The following is a description of a gene set: Cell types are named using anatomical and functional mnemonics prefixed by 'm' or'h' to indicate mouse and human respectively: OMTN, oculomotor and trochlear nucleus; Sert, serotonergic; NbM, medial neuroblast; NbDA, neuroblast dopaminergic; DA0-2, dopaminergic neurons; RN, red nucleus; Gaba1-2, GABAergic neurons; mNbL1-2, lateral neuroblasts; NbML1-5, mediolateral neuroblasts; NProg, neuronal progenitor; Prog, progenitor medial floorplate (FPM), lateral floorplate (FPL), midline (M), basal plate (BP); Rgl1-3, radial glia-like cells; Mgl, microglia; Endo, endothelial cells; Peric, pericytes; Epend, ependymal; OPC, oligodendrocyte precursor cells. Human Gene Set: MANNO_MIDBRAIN_NEUROTYPES_HGABA species: Homo sapiens from publication La Manno G, Gyllborg D, Codeluppi S, Nishimura K, Salto C, Zeisel A, Borm LE, Stott SRW, Toledo EM, Villaescusa JC, Lönnerberg P, Ryge J, Barker RA, Arenas E, Linnarsson S (PMID 27716510), and this is the list of marker genes: BRSK2, BOD1L1, PILRB, MICU3, MAPRE3, PPFIA4, PEX1, POU2F1, BACH2, SSH2, DUSP26, MVB12B, GOLGA8J, LRRC49, PRSS12, AFF3, TMEM255A, RUFY3, SLC24A3, ENSG00000255240, FNBP1L, LRRC2 (leucine rich repeat containing 2), DNM3, FAM81A (NCBI Gene Id 145773), GABRB2, TAFA5, CDRT4, CATSPERG, PCDH9, CSGALNACT1, SGMS1-AS1, SYNPR, STMN2, PPP3CB, PCDH11X, AMER3, SMPD3 (sphingomyelin phosphodiesterase 3), F11R, MARCHF1, NPFF, SOCS7, FAM217B, SNAP91, FRY, CALB2, NRP2, SV2B, BCL11A, STK32B, RFX7, CMIP, EPB41L1, NT5DC3, CDON (cell adhesion associated, oncogene regulated), RUNX1T1, SLC17A6, DACT1, SMIM17, VAV2, C11orf87, MAST4, MEGF6, PLCXD3, CCDC88A, SLC6A1, DIP2B, MAP6, PCLO, DND1, TBC1D3, CLVS2, LRRC3B, AKAP9, WASF1, TSPAN7, HBG2, PXK, GNAL, VSTM2A, AKR1C2, SNTG1, ZNF793, KRT14, AGTPBP1, SORBS1, GABRB3 (NCBI Gene Id 2562), LSAMP, LBH, SHROOM2, PIK3CD, CHST11, FAR2P2, GDPD1 (glycerophosphodiester phosphodiesterase domain containing 1), NCAM1, THSD7A, ACSL6, IRF2BPL, FMNL2, TAFA2, NCR3LG1, RB1CC1, MAGI3 (NCBI Gene Id 57725), KCNQ1OT1, BRWD1, IRX3, GABRG2, CNR1, HPCAL4, RNF146, PIANP, LAMC2, CRIM1, OTP, ZNRF1, LRRC7, TMEFF2, TULP4, CD2, FAT2 (FAT atypical cadherin 2), GNAO1, CACNA1A, CSNK1G2, BZW2, PRRT4, KCNC1, MSR1, MIR3945HG, RAB3B, NDST3, ARL8A, DLG2, ATP1B1, DCX, SEMA6D, NNAT, CGN, CREG2, UNC13A, TMEM74B, NRXN3, CPNE5 (NCBI Gene Id 8901), CADM1, KCNC2, LHFPL3, CACNB3, ST8SIA3, KIAA1549, CCDC112, HOOK1, UBXN2B, FBLL1, MTUS2, AKR1C1, CACNG2, KCNA3 (potassium voltage-gated channel subfamily A member 3), GPRIN3, VSNL1, GNG2, LYSMD2, NBEA, TRIM67, CDH22, SV2C, SNX1, SEMA3A, GRM4, RIMS1, COL6A6, GABPB1-AS1, FAM219A, IKZF4, SMARCC2, EEA1, TMEM163, MED13L (mediator complex subunit 13L), SLC25A22, SDC3, ADARB2, EID2B, ADAP1, ROBO1, FRMD5, FRMD4B, SPATA13, ADAMTS3, HIVEP3, C2CD6, PRLR, MTSS1, DIRAS2, LRP12, PDE1B, PRRT2, SYTL2 (synaptotagmin like 2), RASAL2, PLEKHA1, ANKRD36, CELF6, VPS53, SLC5A3, KCNIP4-IT1, DNER, PCDH17, TRHDE, BLCAP, SYCP2L, CACNA1C, SAMD11, MCF2L, TTC9, CDKL2, ERC2, ENTREP2, CYRIA, CDH13 (NCBI Gene Id 1012), ZC3H8, TNK2, PGM2L1, IKZF3, CHN2, ARFGEF3 (NCBI Gene Id 57221), STOX2, GLRA2 (NCBI Gene Id 2742), SCN2A, LMOD3, CCDC17, UGCG, KBTBD11, MTURN, CSMD3, NTNG1 (NCBI Gene Id 22854), ATP2B2, NECTIN1, MAB21L1, RAI1, PLXNA3, MAP1B, RAB11FIP4, PLXNC1, PRICKLE2, SRGAP1, SMURF1, CD24, GAD2, ADCY1, CYLD, BRD1, SYN3, PLPPR1, SHTN1, LPAR2, RASGEF1B, FHOD3 (formin homology 2 domain containing 3), RASA4, PDZRN4, EBF2, ELAVL4, LRP1B, GRIK2, PACS1, NALCN, THRA, DOK6, EFHC2, AHNAK2, PDIK1L, SARDH, RIMS3, GRIA1, PDZD7, MSANTD3-TMEFF1, KCNN3, DBET, CSRNP3, CACNA1I, IRX2, NPNT, TCEAL5, SEC31B, AHDC1, NEGR1, UBE2Z, SYNJ1, NSG2, MAP2K3, PTPRO, ST8SIA2, MFSD6, CNOT6L, CHST1, PRKAA2, LIN54, TMEM178B, SLITRK4, DOK4, CELF1, PPARGC1A, FNDC5, SRSF12, RALGDS, RBMS3, ATCAY, TANC2, N4BP2, RETREG2, MGAT5, PKIA, DPF1, MAP3K2 (mitogen-activated protein kinase kinase kinase 2), SLC6A15, FNDC9, STRIP1, SIK3, ARHGAP23, BCL2L15, PCDH19, CELSR3, CASKIN1, GOLGA7B, SPINT2, POU3F2, HYDIN, AMER2 (APC membrane recruitment protein 2), GDAP1, SERPINI1, PRNP, PREPL, MUC2, BLID, WNK3, PIAS2, FUT9, SUGP2, OSBPL6, PPP2R3A, MAPK8IP2, ASIC2, KIFAP3, LGR5, FBXO48, COL8A1, RAPGEF5, SLC25A12, DYRK2, TSIX, ZNF318, LHFPL4, GRIA4, CHIC1, TRIM9, KLC1, RTN4, SP4, NAPB, BDP1 (B double prime 1, subunit of RNA polymerase III transcription initiation factor IIIB), PIEZO2, ATP8A1, SSPOP, CSAD, PDZD4, TTC3, CHRNA4, MAPRE2, HS6ST2, RCOR2, PNCK, ASNS, CACNB4, CNTN5, PCDH8, PDE4DIP, LONRF2, CDK5R1, HBE1, JAG2, GFRA1, LARP1B (La ribonucleoprotein 1B), CYTH1, MBLAC2, SNORD116-29, CHD3, SPOCK2, FAXC, ZNF385D, RBM33 (RNA binding motif protein 33), AKAP6, ACSL4, OPRM1, GPRASP1 (G protein-coupled receptor associated sorting protein 1), SLC7A14, TAOK3, PRDM2, NAP1L2, OGDHL, POU2F2, SHOX2, DCLK3, LRRC4B, RGS6, TARBP1, NOVA1, PRAMEF1, SRGAP3, LPCAT4, CALN1, TCERG1, MICAL3, ABCC5, PWAR1, AP3B2, SPOCK1, RNF157, PRKAB2, EPHB1, CEMIP, KCNIP4, GPR26, SGK2, LINGO1, SEMA3C, TNKS, FAM184A, TTN, SLC9A6 (NCBI Gene Id 53362), DOK3, KIF21B, UBQLN2, BEND4, NOL4L, GPR176, RAB3A, TAC1, DOCK3, FKBP15, FAM114A2, RIMS2, TERF2IP, MYO5A, GPC2, MTUS1, B3GALT2, RBFOX3, RYR2, MYT1L, SPOCK3, ANO8, SLC16A9, DPYSL3, RBM26, ACVR2A, ADGRD1, CHGA, NXPH2, PSD2, ENOX1 (ecto-NOX disulfide-thiol exchanger 1), ABR, GOLGA3, PAK3, GALNT15, SLC32A1, BIVM-ERCC5, DOP1B, TENM1, VASH2, BDNF, SLITRK5, ATL1, CLCN4, NFASC, MAGI2, CXCL5, RUNDC3B, RUSC2, MCF2, ZMYND8, REV3L, PPP2R2B, KCNK2, EHD4, ENSG00000254951, ESRRG, B4GALNT4, GATA3 (GATA binding protein 3), GABRG1, RNF112, ZNF697, FAM43B, CELF4, TMEM121B (transmembrane protein 121B), BSN, MIR124-2HG, DPP6, SVOP, GAD1, MEG3, NALF1, GABRA1, OTUD4, ARL4C, TNRC6A, SST, IDS, KIF13A, SCN3A, SAMD8 (sterile alpha motif domain containing 8), SIX3, SHISAL1 (NCBI Gene Id 85352), CCDC186, CEP85L, NLGN4X, ARID4A, GRIA2, SULT4A1, RAP1GAP2, NEDD4L, NPTXR, ANK3, CRMP1, ZNF28, CACNA1G, XKR6, UBN2, PLXNA4, ELAVL2, NLGN1, CREBRF, ENC1, TES, DOCK4, NETO1, LONRF1, SH3KBP1, NDRG4, SECISBP2L, RAPH1, TNRC6C, PCDHB4, TSPYL4, GNAZ, OPTN, CBX4, MDGA2, VAV3, DHX33, CPEB4, GRK3, SCIN, SLC6A17, SSTR2, DAAM1, APBA1, CELF2, EPHA3, TCEAL2, CCDC184, ARHGAP35, AP1S2, SH3PXD2A, NRXN1, TBC1D2B, GRM5, ARMH4, PDE4C, DNAJC12, ZMAT1, MYO7A, CCDC141, RABGAP1L, NAP1L3, AUTS2 (activator of transcription and developmental regulator AUTS2), NELL1, ARHGAP24, MACO1, EN2, C17orf67, ZFHX2, ABCA3, ADAMTSL4-AS1, ZFHX3 (NCBI Gene Id 463), SAMD5, NREP, NAP1L5, SYT13, ZBTB43, HNF1B (NCBI Gene Id 6928), OLFM1, GPD1L, TTC9B, SPEG, CEP126, NINL, SOX11, ZCCHC12, STEAP2 (NCBI Gene Id 50630), RUNDC3A, INSYN2A (inhibitory synaptic factor 2A), CAMSAP2, ARPP21, ACVR1B, PTPN5, DSCAML1, CHN1, TVP23C, AP1S3, SRRM3, SLC4A8, SORCS3, RICTOR, LPIN1, EFNA5, SLC4A3, KSR2, PNMA8B, SYT4, MYT1, GRID2, SCD5, STMN4, CSMD2, JPH1, RGS7BP, HYCC2, CASK, TAL1, ICA1L, RGS17, PCP4, NRXN2, DLG3, SRCIN1, KLF7, YWHAG, DNAJB14, UCHL1, TMEM185B, KIF3A, INPP4A, NPAS3, LGI2, KLHL14, NGEF, ATRX, PCOLCE2, GRIN3A, ZBTB38, CA1 (carbonic anhydrase 1), KDM2B, NMNAT2, APBA2, CDC42EP3, ZNF462, MPP3, SCN9A, ATP9A, SRRM4, PDE7A, CADM3, TMEM132B, KIF21A, RETREG1, TMEM151A, SH3BP5, PLCB4, GPM6A, DNM1, IGSF3, CITED2, DMTN, SCN8A, BIVM, PCDHA7, UBE2QL1 (NCBI Gene Id 134111), TMEM35A, RIMBP2, TCERG1L (transcription elongation regulator 1 like), DACT3, CPEB2, XPR1, MTMR6, ARK2C, SPAST, C3orf62 (chromosome 3 open reading frame 62), ZYG11B, SLITRK1, NKAIN2, HCFC2, ARFGEF1, TBC1D9, PPP2R2C, FAM117B, SSBP3, KHDRBS3, LSM11, PNMA2, DNAJC6, PPARGC1B, PNOC, SV2A, SHANK3, VGF, DGKE, NCS1, PTPRK, KIF1A, CNTN4, SBF2, CNTN1, PLXNA1 (NCBI Gene Id 84202), DICER1, MAP3K9, SEZ6L2, CBLN4, STXBP1, FGF14, MIA3, ZNF471, HERC1, PAK5, TPD52L1, RALGPS1, ARHGEF12, GAP43, CSMD1, PRKAR2B, NALF1-IT1, ANK1, B3GAT1, GPR155, PAPPA, KIAA1549L, MAP7D2, PDE1A, MARK1, PEG3, GRIP1, ZNF32, SYT6, PBX3, RTN1, SLC37A1, CHRM5, WT1-AS, ABLIM3, IGSF9B, UBE2Q2, PEX5L, THEM4, TTC14, EBF1, CERS6, CAMK2N2, CCDC85A, PCGF3, VCAN, CYP4X1, PRDM8, SLC38A1, SOBP, EPB41, CTNNA2, ETS2, TLN2, YPEL2, PPP1R9A, PCDH7, CBLN2, TMOD2, SIN3A, ST8SIA4, GNPTAB, GDAP1L1, FRMD3, SNORD11, XKR4, TMEM196, ROBO2 (roundabout guidance receptor 2), DCC, KHDRBS2, TSPOAP1, FAM169A, MDGA1, R3HDM1, EBF3, KCTD7, TTLL7, MIAT, RUFY2, TMEM229B, CADPS (calcium dependent secretion activator), HNRNPCL3, PFKP, TUT4, OPCML, FAM216A, ZNF77, VWA5A, RFK, PDE11A, ANKRD44, CELF3, SOX14, JPH4, SLC22A4, TENM2, COL11A1, TRIM58, PRRC2B (NCBI Gene Id 84726), SLC9A7, STXBP5, PDXP, CXADR, BEX2, GK5, CASZ1, SLC22A15, RIPOR2, RUNDC1, SCN1A (NCBI Gene Id 6323), ERC2-IT1, WDR97, LANCL2, UBASH3B, FNBP1, SEZ6L, CACNG8, SCAI, ACTL6B, SERINC5, CABP4, RFPL3S, DNAJC16, CCPG1, CDH4, MDN1 (midasin AAA ATPase 1), GOLGA8B, ANKRD36B, LRFN5, ASXL3, GUCY1A1, ZNF248, TOX3, FAM171B, SLC8A1 (NCBI Gene Id 6546), FOXD4L5, TRIM46, FGF7P3, CHSY3, GPR137C, ANKAR, BRF1, GALNT12, SLC8A2, RUSC1, FRS3, CTNND2, PITPNC1, C2CD5, ANKRD12, NCAN, DOP1A, HS6ST3 (NCBI Gene Id 283476), ARNT2, RELN, GRM7, SNAP25, COMTD1 (NCBI Gene Id 118881), SLC16A14, ACVR2B, PPFIBP1, CAPRIN2, AATK, PRKCA, PAQR8 (NCBI Gene Id 85315), SLC12A5, KCNQ3, CDKN2D, BCL11B, NXPH1, ZGLP1, AATBC, GPR85 (NCBI Gene Id 54329), LHX1, TRIM2, BASP1, XK, MAST1, DCLK1, NOL4, PCDH1, PYCARD-AS1, FRMPD4, GPR12, ST3GAL5, NLK, GOLGA8A, CSPG5 (NCBI Gene Id 10675), UNC79, LZTS3, CHD5, MAP2, NUAK1, ANKS1B, ZNF354A, GRM1, JPH3, NFIX, CLVS1, PDE4D, NPDC1, HBB, XIST, SAMD14, SALL4, CDH8, NCOA7, NOX4, ADAM23, ANKRD18A, WAC-AS1, GRIP2, GFOD1, KRT222, PHACTR3, MMP24, LRRK2, RFPL1S, FGF12 (fibroblast growth factor 12), NIPA1, ZBED10P, GIGYF1, KLHL13, LRRN3, RAB22A, MLLT3 (MLLT3 super elongation complex subunit), FBXL16, RHOT2, XPA, NSG1, GSE1, LAMA3, CYFIP2, STIM2, CAMK2B, ST6GAL2, PGAP1, ITGA8, AFF2, SYP, APLP1, PRKCB, NRSN1 (NCBI Gene Id 140767), EEF1A2, AGAP12P, ERAP2 (endoplasmic reticulum aminopeptidase 2), CEND1, SYNGR3, SNORD12, ANO5, BLTP3B, INA, TBC1D32, CACNG4, KMT2E, DCLK2, PIP4K2B, SLC39A12, KIFC2, TATDN2, NLN, FOXN3, PTEN, ZFPM2, LUC7L, SYBU, TBC1D24, GABBR2, IRX1, TUBB3, GRM3, TOX2 (TOX high mobility group box family member 2), MPPED2, HSPA12A, ATP2B1, CELF5, PRSS53, SPAG17, PRKACB, RAPGEF6, SLC24A2, APC2, GPR158, HCN3, CPEB3, GRIK3, ADGRB1, TUBB2B, PRKAR1B, TMEM169, NUTM2A, LRATD1, RAB9B, SLCO3A1, RALYL (RALY RNA binding protein like), SHC4, KIF5C, TMEM59L, CCDC144A, VHL, CAMK2N1, AJAP1, PSD, GRID1, AGAP1, SYN2, SCN3B, PRKCZ, ANK2, ANKIB1, NTRK3, WNT7A, SBK1, C1orf35, MEGF9, FADS3, CACNA1E, TLL1, PPP3R1, PABPC1L2A, ZFHX4, SYT1, TMCO3, REEP1, MLLT11, NAV1, SEMA3E, IGFN1 (immunoglobulin like and fibronectin type III domain containing 1), ELAVL3, PDP1, SLC1A2, TLCD3B, DSCAM, OCRL, NEB, PTPRT, TSHZ2, SMG1P3, A2M-AS1, ADGRL1, PPFIA2, TSC2, CNTNAP4, PAX5, SERINC1, DUSP4, RBFOX1, ZMIZ1, MYCBP2, HERC2P2, NAV3, HERC2P4, NTM, CADM2, SHANK2, OLFM3, KCNMA1 (potassium calcium-activated channel subfamily M alpha 1), CCSER1, PLEKHA6, KBTBD6, ADGRL3, CLIP1, LYST (lysosomal trafficking regulator), PLPPR4, CERT1, USP49, LAMA5, KIF3C, OPN5, PTBP3, ZNF816, GRIK1, RBFOX2, SLC4A1, CAMTA1, MGAT4C, RORA, VWCE, IRGQ, L1CAM, FGF9, ZNF663P, CNTNAP2, MUC19, FRMPD3, APC, GNAQ, NCDN, ZNF264, CHL1, LINC00205, FSIP2, BACE1, ATP1A3, TNFSF13B, LRRTM2, KCNH8, GABRA2